Given this list of marker genes UFM1, BRCA1, VPS11, FOXA1 (NCBI Gene Id 3169), UFSP2, PAK1, CDK12, PARP1, AR, STRN3, KMT2D, PAGR1 (NCBI Gene Id 79447), LBH, TP63, VPS18, SRARP, SRC, SKP2, HDAC1, LATS1, UBA5, ISL1, DDRGK1, FSHR, HDAC2, PHB2, MED1, CNOT2, KANK2 (NCBI Gene Id 55598), UFL1, CARM1, WBP2, ZNF366, CNOT1, CYP7B1, CNOT9, DNAAF4, HDAC6, here is a description of the gene set: Human Gene Set: GOBP_REGULATION_OF_INTRACELLULAR_ESTROGEN_RECEPTOR_SIGNALING_PATHWAY studied in species Homo sapiens Any process that modulates the frequency, rate or extent of the activity of an intracellular estrogen receptor signaling pathway.